The following is a description of a gene set: The movement of a T cell within or between different tissues and organs of the body. studied in species Homo sapiens Human Gene Set: GOBP_T_CELL_MIGRATION, and this is the list of marker genes: ICAM1, TMEM102, DEFA1B, CCR2, WNK1, ADAM17, STK39, ITGA4, CD200, FADD, LGALS9, PYCARD, PIK3CD, TNFRSF14, CXCL11, DEFA4, ECM1, WNT5A, RIPK3, ADAM8, APP, ZAP70, CCL3, ASCL2, MED23, CCL21, SPN, LRCH1, SPNS2, XG, RHOA, OXSR1, CCL5, AIRE, MSN, FUT7, CXCL10, TNFSF14, SELENOK, CRKL, ABL1, CCL20, CD99, XCL1, PLEC, PIK3CG, DOCK8, CXCL12, CXCL13, SLC12A2, RIPOR2, ITGAL, CD200R1, CCR6, ITGB7, MYO1G, CORO1A, S1PR1, F11R, GPR15LG, CRK, CCL26, CD99L2, CD69, IL27RA, GPR15, CXCL16, ITGB3, AIF1, S100A7, CXCR3, P4HB, ABL2, GPR183 (NCBI Gene Id 1880), APOD, CCL2, ADAM10, GNAI1, DEFA1